Given this list of marker genes Slc25a29, Slc7a3 (NCBI Gene Id 11989), Slc7a1, Slc47a1, Slc7a6, Slc47a2, Slc25a15, Slc22a2, Slc38a9, Slc66a1, Slc38a4, Slc7a7, Slc25a2, Slc7a2, here is a description of the gene set: Enables the transfer of L-arginine from one side of a membrane to the other. Mouse Gene Set: GOMF_L_ARGININE_TRANSMEMBRANE_TRANSPORTER_ACTIVITY studied in species Mus musculus